Given this list of marker genes DKC1, TP53, TERT, TERC, KRT6C, NOP10, TYMS, GJB2, DCLRE1B, PARN, CAST, MEFV, KRT4, RHBDF2, CTC1, KRT6A (NCBI Gene Id 93086), KRT16, USB1, KRT17, TINF2, RTEL1, NHP2, WRAP53, KRT6B, ACD, NPM1, RPA1, FERMT1, here is a description of the gene set: White lesion of the oral mucosa White lesions of the oral mucosa are generally caused by a condition that increases the thickness of the epithelium. This increases the distance to the vascular bed and thereby tends to change the usual reddish color of the oral mucosa to white. Common causes include hyperkeratosis (thickening of the keratin layer), acanthosis (thickening of the spinous cell layer), increased edema in the epithelium (leukoedema), and reduced vascularity of the underlying lamina propria. Additionally, fibrin caps or surface ulcerations and collapsed bullae can appear white. studied in species Homo sapiens Human Gene Set: HP_WHITE_LESION_OF_THE_ORAL_MUCOSA